The following is a description of a gene set: studied in species Homo sapiens The mitochondrial branched-chain alpha-ketoacid dehydrogenase (BCKDH) complex catalyzes the reactions of alpha-ketoisocaproate, alpha-keto beta-methylvalerate, or alpha-ketoisovalerate with CoA and NAD+ to form isovaleryl-CoA, alpha-methylbutyryl-CoA, or isobutyryl-CoA, respectively, and CO2 and NADH. While bovine and microbial BCKD complexes have been characterized most extensively, structural studies of individual components and subcomplexes of human BCKD have confirmed their structures and roles in the overall oxidative decarboxylation process and have related these features to the disruptive effects of mutations on branched-chain amino acid metabolism in vivo: E1a and E1b components, E2, and E3 (DLD). In addition, structural studies have confirmed the lipoylation of lysine residue 105 in E2 protein and the loss of an aminoterminal mitochondrial transport sequence from mature E3 protein. Loss of mitochondrial transport sequences from proteins E1a, E1b, and E2 has been demonstrated by sequence analysis. Defects in E1a, E1b, and E2 may cause so-called maple syrup urine disease, with accumulation of the abovementioned amino acids and their corresponding keto acids, leading to encephalopathy and progressive neurodegeneration (MSUD, MIM:248600; reviewed in Xu et al., 2020). Defects in the E3 (DLD) subunit, shared with other ketoacid dehydrogenase complexes, typically present as neonatal lactic acidosis due to lack of pyruvate dehydrogenase activity although symptoms of BCKDH deficiency may also be present. Reactome Pathway: BCKDH synthesizes BCAA-CoA from KIC, KMVA, KIV part of: Branched-chain amino acid catabolism, and this is the list of marker genes: BCKDHB, DBT, DLD, BCKDHA